Given this list of marker genes VWA5A, STAT3, ARID2, MBD4, TRNT1, RBP4, NRG1, GPR182, CDH7, SLC35E4 (solute carrier family 35 member E4), KBTBD2, PLAGL1, TFB1M, MS4A1, SLC25A4, C14orf28, KCNQ3, EMC3, GEM, RABL3, KCTD16, KAT6B, ZNF451, KCNC2, ASB5 (ankyrin repeat and SOCS box containing 5), SPX (NCBI Gene Id 80763), ARID3B, CCDC178, PTPRC, TRIM35, SDCBP, GOLPH3, ERAP1, CFAP95, TRIM33, ATP2C1, USP38, DCLRE1B (NCBI Gene Id 64858), TEX10, YY1, PTPN21, SLC35D3, MGAM2, SLAMF7, MINDY2, DRD1, PHACTR4, COL19A1, CYB5B, YTHDF3, CFAP300, KLHL24, FAXC, CUL2, RLIM, SHANK2, CFDP1, MBNL2, DLC1, OSBPL8, DMXL1, RAB12, NAB1, SOX6, PRDM1, KRTAP4-2, MEOX2, GUCY1B1, here is a description of the gene set: from publication Chen Y, Wang X (PMID 31504780) studied in species Homo sapiens Genes predicted to be targets of miRBase v22 microRNA hsa-miR-4662a-3p in miRDB v6.0 with MirTarget v4 prediction scores > 80 (high confidence targets). Human Gene Set: MIR4662A_3P